Given this list of marker genes ISLR2, PDYN, RAPGEF3, PROKR1, C11orf87, ADAMTS16, GAS2L2, BRINP3 (NCBI Gene Id 339479), PTGFR, TMEM26, TCAM1P, TGFB3, KCNJ5, PIWIL2 (piwi like RNA-mediated gene silencing 2), FXYD5, CORO1A, CHODL, EVPL, SGCD, TBATA, CDHR4, KCND2, CCDC38, GNAT1, RGS8, GPAT2, PHYHIP, CNTNAP1, SEZ6L2, FIBIN, PAMR1, LYL1, ETV2, ZNF608, LTA, CCER1 (NCBI Gene Id 196477), SPTSSB, OPCML, HOXB13, PTN, GRM3, VRTN, PCARE, TNFRSF13C, IGF1, AVPR1B, NOL4, NPY1R, PAK5, PTGS1, ZNF354B, COL4A3, AQP2, RHOJ, BEST2 (bestrophin 2), LEFTY1, PVALB, MARCHF1, ADARB2, ESRP1, MCHR1, RNF207, PAPLN, TNFRSF8, EDN2, WNT8A, KLHL1, TFPI2, MST1R, TMEM45B, PSMB11, NCAN (neurocan), FGL2, LAMA4, REM2, EPN3 (NCBI Gene Id 55040), MOGAT1, PTH2R, UCP1, PDE1C, MYL7, CD44, SLFN5, CDKN2C, SULT2B1, COL4A4 (NCBI Gene Id 1286), PAX5, GPNMB, SUSD4, ISLR, ABCC3, MFSD2B, APBB1IP, AQP6, HSPA12B, CNMD, ADAM33, TLR5, COX4I2, CIITA, SCNN1A, NOL3, NR5A1, EXTL1, SLITRK1, GPR84, TLR12P, KCNJ2, TEKT2, CRABP2, TSPAN11, PDE11A, GGT7, PDE8B, CACNG3, MYZAP, NRBP2, DKK1, CLEC14A, LOXL3, OSM, MELTF, TSSK3, PRSS36, IDO1, GUCY1A1, KCNN3, DSC3, RFLNA, COL1A2, SPINK2, CHST3, NPY2R, PCDH20, ALOX15B, FGF10, here is a description of the gene set: We report the application of single-molecule-based sequencing technology for high-throughput profiling of histone modifications in mammalian cells. By obtaining over four billion bases of sequence from chromatin immunoprecipitated DNA, we generated genome-wide chromatin-state maps of mouse embryonic stem cells, neural progenitor cells and embryonic fibroblasts. We find that lysine 4 and lysine 27 trimethylation effectively discriminates genes that are expressed, poised for expression, or stably repressed, and therefore reflect cell state and lineage potential. Lysine 36 trimethylation marks primary coding and non-coding transcripts, facilitating gene annotation. Trimethylation of lysine 9 and lysine 20 is detected at satellite, telomeric and active long-terminal repeats, and can spread into proximal unique sequences. Lysine 4 and lysine 9 trimethylation marks imprinting control regions. Finally, we show that chromatin state can be read in an allele-specific manner by using single nucleotide polymorphisms. This study provides a framework for the application of comprehensive chromatin profiling towards characterization of diverse mammalian cell populations. Genes with intermediate-CpG-density promoters (ICP) bearing bivalent histone H3 methylation mark (H3K4me3 and H3K27me3) in embryonic stem cells (ES). species: Mus musculus Human Gene Set: MIKKELSEN_ES_ICP_WITH_H3K4ME3_AND_H3K27ME3 from publication Mikkelsen TS, Ku M, Jaffe DB, Issac B, Lieberman E, Giannoukos G, Alvarez P, Brockman W, Kim TK, Koche RP, Lee W, Mendenhall E, O'Donovan A, Presser A, Russ C, Xie X, Meissner A, Wernig M, Jaenisch R, Nusbaum C, Lander ES, Bernstein BE (PMID 17603471)